The following is a description of a gene set: studied in species Mus musculus Genes containing one or more binding sites for (Hlf) in their promoter regions (TSS -1000,+100 bp) as identified by GTRD version 20.06 ChIP-seq harmonization. from publication Yevshin I, Sharipov R, Kolmykov S, Kondrakhin Y, Kolpakov F (PMID 30445619) Mouse Gene Set: HLF_TARGET_GENES, and this is the list of marker genes: Slc11a1, Rimoc1, Slc27a2, Rdh11, Sez6, Nsun4, Etfrf1, Lrrc40, Snora44, Mapk11, Myef2l, Spi1, 1110018N20Rik, Gm2093, Aacs, C5ar2 (complement component 5a receptor 2), Lztfl1, Wdr90, Tmbim6, Gm26839, Eola1, Slc23a2, Gm11729, Rab40c, Btf3l4, n-R5s41, Nepro, Psme1, Nadk, Dusp14, Dqx1, Ppt1, Fam78a, Tmem131l, Slc33a1, Fbll1, Cdc123, 2310001H17Rik, Tbc1d10b, Ifi47, Gm15581, 1200007C13Rik, Bod1l, Rbpms, Ifngr1, Syt14, Nlrc4, Dennd1b, Zfand4, Gm11335, Rap2a, Top1, Spns3, Cep295, Id1, Vgf, Runx2os2, Vgll4, AA465934, Nlrp3, Qtrt2, Kcnq3, Baz1b, Retreg1, Gm15346, Fstl5, Bcl2l15, Gm9408, Acss2, Foxp1, Sp3, Etfbkmt, Trav16, Clp1, Mir9-3hg, Sec24a, Fam120b, D330050G23Rik, Aip, Aldh3b1, Gm17597, Pi16, Hnrnph3, Ccdc191, Mfsd4b3-ps, Usf1, Mfsd11, Tarm1, Lonp2, Dusp16, Man1b1, Ptcd1, Trpm8, Ifrd1, Coasy, Slc35e3, Ip6k1, Tmt1a, Gna14, Gm16897, Nt5c3, Gm27252, Trib1, Fktn, Got1, Ccl3, Nrxn1, Ccl9, Scrib, 4931440P22Rik, Atp1b1, Kctd20, Alg11 (ALG11 alpha-1,2-mannosyltransferase), Usp48, Rab43, Timm21, Dennd2d, Meis1, Foxj3, Slamf9, Osbp2, Dclre1c, Gm15764, Cox7a2, Zdhhc18, Dars2, Irs2, Or10aa1, Cacnb2, Dnai7, Lman2, Lrrc73, Polr2b, Rab27a, Cldn12, Tbc1d23, Sf3b2, Cd47, 1700058P15Rik, Gm26812 (NCBI Gene Id 102637329), Best1, Tpk1, Havcr2, Eif5a, Bmf, Serpine2, Dbi, Mir1938, Ptprs, Ormdl3, Gmfg, Gm13546, 4930430E12Rik, Ctsl, Atp7b, Esrra, Apbb1ip, Marchf7, Ube2m, Gm15423, Gm17102, Mideas, Lrrc61, Actr3, Tef, Gm14221, Zfp386, 4930412M03Rik, Pabpn1, Macir, Cox5a, Wasf1, Gsr (NCBI Gene Id 52270), Mtfp1, Nfe2, Dhx33, Pml (promyelocytic leukemia), Safb (scaffold attachment factor B), Plppr2, Cwf19l2 (CWF19 like cell cycle control factor 2), Gbp5, Gcnt1, Zfp513, Lhfpl5, 1700030J22Rik, 2900009J06Rik, Entpd7, Wdr70, Ccni, Pank1, Chpf, Cenpu, Slc6a6, Dnajb11, Sergef, Snora16a, Inpp5a, Card9, Itgb5, Gdap1, Uqcrc1, Aftph, Htr1a, Gmfb, Sumo2, Rnf13, Epb41l4b, AA914427, Zbtb7a, Fgd3, Hsd11b1, Sirpa, 1700041G16Rik, Cd27, Ccdc97, Chd4, Srsf2, Srrm3, Il17d, Rnf149 (ring finger protein 149), Birc2, Slc45a4, Pck2, Adcy7, Per1, Samsn1, Mphosph10, Stxbp3, Mcee, Pax5, Mrps36-ps2, Bdnf, Cenpl, Tspoap1, Tnfrsf23, Aldh8a1, Tmem62, Bace1, Snhg12, Clec4a2, 5930430L01Rik, Itgal, Arid4a, Hrh3, Marveld1, 3110056K07Rik, E2f8, Noa1, Mrpl11, Map2k7, Gstt1, Clec12a, Rpe, Gm20443 (predicted gene 20443), Mlkl, 4933406J10Rik, Unc13a, Psmd4, Misfa, Slx4, Dgat1, Irf2bp1, Med1, Cd84, 5031434O11Rik, Paqr7, Per2 (period circadian clock 2), Grin1, Psmb3, Fnbp1, Gm28809, Rhbdd3, Hcar2, Dnaaf10, Tbc1d4, Hjurp, Cpsf4, AI987944, Pbld2, Itgb3bp, Hdgf (heparin binding growth factor), Kcnq5, C130050O18Rik, Tmem198, Ubp1, Celf6, Smad3, Brap (NCBI Gene Id 72399), Dynlt2b, Scn2a, Galnt9, Vwc2l, Mbnl1, Kcnb1, Mir8120, Gm13073, Cytip, Pold1, Rin3, Ralgds, Ppil3, Pira12, Tmem222, Txndc12, Ccp110, Rundc3a, Hmgn2, Gpsm2, Alox5ap, Blnk (NCBI Gene Id 17060), Bltp3a, Pdss1, Ptgs2os2, Nptxr, Sephs2, Evi5, Rcc2, Rnf24, Sec62, Kctd11, Tnrc18, Scrt1, Gm20324